The following is a description of a gene set: studied in species Mus musculus Human Gene Set: HOWLIN_CITED1_TARGETS_1_DN from publication Howlin J, McBryan J, Napoletano S, Lambe T, McArdle E, Shioda T, Martin F (PMID 16278680) Expression microarray analysis identified CITED1 among a group of genes specifically upregulated in the pubertal mouse mammary gland. At puberty, CITED1 localizes to the luminal epithelial cell population of the mammary ducts and the body cells of the terminal end buds. Generation of CITED1 gene knockout mice showed that homozygous null mutants exhibit retarded mammary ductal growth at puberty and, in addition, dilated ductal structures with a lack of spatial restriction of the subtending branches. Analysis of CITED1 homozygous null and heterozygous null mammary gland gene expression using microarrays suggested that the mammary-specific phenotype seen in the homozygous null females is due to a disturbance in the transcription of a number of key mediators of pubertal ductal morphogenesis. These include estrogen and TGFbeta responsive genes, such as the EGFR/ErbB2 ligand, amphiregulin, whose transcription we suggest is directly or indirectly regulated by CITED1. Genes down-regulated in mammary glands from the CITED1 knockout mice: homozygotic vs. heterozygotic animals., and this is the list of marker genes: IER5, SC5D, PALS1, JAK1, VPS53, RAD51AP1, RNF14 (NCBI Gene Id 9604), CITED1, HGF, ANGEL2, SERINC1, ASPH (aspartate beta-hydroxylase), AKR1B1, FAM9A, ABCB7, MPZL2, CDH11, IDO1, BTBD1, NR1D2, THBS1, GALC, UAP1, AMACR, TRIM34, PDGFD, TFRC, CLCA2, ATP1A2, NABP1, RAB6B, SYT13, EPB41L2, LIN7C, SLC25A24, TMEM30B, HIF1A, CRYAB, CAP1